Given this list of marker genes MT-ND4, SLC18A2, SUCLA2 (succinate-CoA ligase ADP-forming subunit beta), L2HGDH, ACADSB (acyl-CoA dehydrogenase short/branched chain), MYCN (MYCN proto-oncogene, bHLH transcription factor), SLC25A19, MT-ND1, MT-ND2, KYNU, HSPD1, PEX1, MMUT, MCCC2, MVK, MCEE (NCBI Gene Id 84693), CPT1A, MT-ATP6, NDUFA9, OXGR1, ALDH5A1, PET117, LIN28B, LIPT1, ETHE1, MLYCD, GATA1, AGXT, UROS, SCO2 (synthesis of cytochrome C oxidase 2), SLC34A1, COX16, SLC6A19, PRDX1, NFS1, GCDH, NFU1, BCKDHA, SLC25A21, SLC26A1, BTD, SLC52A1, ALK, DDC, DHTKD1, ACSF3, ABCB7, HADH, ABCD4, HMGCS2, D2HGDH, PCCB, ACADVL, OXCT1, SLC25A4, HACE1, ACADS, CA5A, NDUFS4, HOGA1, PEX14, FTCD, MTR, HLCS, HMBS, TRMU (tRNA mitochondrial 2-thiouridylase), FBXL4, GRHPR, MCCC1, SLC22A5, IDH1, LDHD, PHOX2B, ALDH6A1, ACAD8, MMADHC, CD320, SLC52A2, MRPL39, ETFDH, MT-TK, MMAB (NCBI Gene Id 89909), SFXN4, ALDH4A1, SLC13A3, SLC25A20, POLG, LETM1, ETFB, COQ4, KIF1B, PGM2L1, TMEM126B, ECHS1, ATPAF2, BCS1L, HPD, FH, MTRR, ACAD9, EHHADH, HGD, SUCLG1, TAMM41, UPB1, TAT, POLRMT, SLC35C1, MT-TW, FDFT1, IVD, MRPS2, MT-TL1, SUGCT, MT-ND6, CPOX, TEFM, PAH, PDP1, ALAD, PCCA, TCN2, MT-TV, MT-ND3, IDH2, HMGCL, HCFC1, FOCAD, LYRM4, MMACHC, LMBRD1, NDUFB10, SCO1 (synthesis of cytochrome C oxidase 1), SDHD, SLC25A1, MMAA, ACADM, CPT2, UROC1, NADK2, MT-ND5, FLAD1, RET, LMO1, TFAM, MPV17, ETFA, PPOX, MPC1, NDUFAF6 (NADH:ubiquinone oxidoreductase complex assembly factor 6), GATM, here is a description of the gene set: Abnormal urine pH studied in species Homo sapiens A deviation of urine pH from the normal range of 4.5 to 7.8. Human Gene Set: HP_ABNORMAL_URINE_PH